The following is a description of a gene set: Mouse Gene Set: GOBP_ESTABLISHMENT_OF_SPINDLE_ORIENTATION studied in species Mus musculus Any process that set the alignment of spindle relative to other cellular structures., and this is the list of marker genes: Sapcd2, Numa1, Arhgef2, Mad2l1, Spry2, Spry1, Dynlt1b (dynein light chain Tctex-type 1B), Nsfl1c, Fgf10 (fibroblast growth factor 10), Ndel1, Clasp1 (CLIP associating protein 1), Pkhd1, Llgl2, Plk1, Gpsm2, Fbxw11, Zw10, Pafah1b1, Cdk5rap2, Spdl1, Bccip, Llgl1, Mcph1, Ska3 (NCBI Gene Id 219114), Pax6, Cenpa, Inppl1 (inositol polyphosphate phosphatase-like 1), Spag5, Htt, Itgb1, Ska1, Ubxn2b, Kat5, Ankfn1, Ccdc66, Mapre1, Hdac3, Gja1 (gap junction protein, alpha 1), Gpsm1, Misp, Ndc80, Dctn1, Ska2, Map4, Nde1, Mos, Enkd1